The following is a description of a gene set: Human Gene Set: GOMF_N_ACETYL_BETA_D_GLUCOSAMINIDE_BETA_1_3_GALACTOSYLTRANSFERASE_ACTIVITY species: Homo sapiens Catalysis of the reaction: an N-acetyl-beta-D-glucosaminyl derivative + UDP-alpha-D-galactose = a beta-D-galactosyl-(1->3)-N-acetyl-beta-D-glucosaminyl derivative + H+ + UDP., and this is the list of marker genes: B3GALT4, B3GNT2, B3GNT7, B3GNT5, B3GALT1, B3GNT8, B3GALT5, B3GNT3, B3GALT2, B3GNT4, B3GALNT1, B3GNT6